Given this list of marker genes ZDHHC17, CDON (NCBI Gene Id 50937), GOLGA8J, ANO1, LIMCH1, RAB8B, FAM3C, GSE1, GOLGA6L4, SLC7A11, PITPNB, CCL8, PPIP5K2 (diphosphoinositol pentakisphosphate kinase 2), GTSE1, CNOT2, CHMP2B, TNS1, HAO1, PRKCD, KIF3B, PTPN22, TOM1L1, LIG4, SEC24C, GPD1L, ZNF586, MBOAT2, PAWR, EPC2, DEPTOR, PLAG1, SLC25A36, NCOA2, TAB3, IRS2, ZNF189, CHIC1, TBCEL (tubulin folding cofactor E like), CPOX, PAX5, NSUN7, ONECUT2, RIOX2, OXGR1, ZNF584, PALS1, PDE5A, GPBP1, ADRA1A, ETFBKMT, CALM1, GIGYF1, PCDHA6 (NCBI Gene Id 56142), KLHL42, TBC1D14, EPHA4, GCC2, LIN28A, LPCAT2, ZFP1, TTC39B (NCBI Gene Id 158219), ZNF544, ZFAND4, NLK, MAP2K1, RNF169, BIRC6, WDR82, TMEM64, DMXL2, MAMDC2, ACSL4, PHF3, MAPK1IP1L, TCF7L2, QKI, GHITM, ESR1, HECA, HRH1 (NCBI Gene Id 3269), TMLHE, KANK1, GOLGA8R, FIGN (fidgetin, microtubule severing factor), ZNF559, NOTCH2, OOSP2, LAMA1, ASTN1, GOLGA1, UBP1, SLC35F3, ZNF426, TAFA2, NAA50, NPEPPS, JARID2, FSBP, MSANTD3-TMEFF1, ATP8B2, SPRY4, TRIM2, IQCJ-SCHIP1, KDM5A, RLIM, RASSF8, POLQ, ACER3, C2orf69, PNRC2, ZEB2, RFC1, ADGRB3, ANKRD13C (NCBI Gene Id 81573), ARF6, PCDHAC2, GRB10, ATP2B2, PPP2R3A, TNF, SYNPR, KCNJ10, BOLL, DERL1, HIPK3, SCHIP1 (schwannomin interacting protein 1), ATMIN, ADAM11, IGF2BP2, CBLB, KLF15, ASPH, GPD2, HMBS (NCBI Gene Id 5448), ETNK1, PLCL2, PRDM4, ZNF844, RAD54B, MYO1E, GRM5, LOX, KLF6, BRWD1, PPP3R1, SOWAHA, SS18L1, BAG4, KPNA1, PLEKHJ1, RAB3IP, KLHL2, ATXN3, NOVA1, KATNBL1, ADCY1, ZIC2, ZNF121, ZNF527, MTPN, PTBP3, EYA3, GABRA1, TBC1D1, MIDEAS, TNRC6B (trinucleotide repeat containing adaptor 6B), MGAT2, S1PR1, CPNE2, NR6A1, KCNQ5, SYT16, GPR137C, DNAJC3, SLC2A3, NEXMIF, PCDHA11, KCNA1, ZNF37A, SLC38A11, YTHDC2, MFSD6, FAM135A, CPD, CREB1, ARHGEF3, TMEM94, UBE2B, REPS2, CCP110, RASSF1, NOTCH4, MB21D2, CXCL9, FNIP2, LIN28B, CEP97, GATA6, TMEM144, ATP2B3, HEY2, CHMP1B, LYRM1, HOXC8, PDE3A, N4BP2, GOLGA8M, PCDHA1, GOLGA8Q, ZBTB4, CREBRF, ADAMTS5, E2F7, WNK1, ZNF594, SIPA1L2, TNFSF4, PHF20L1, MED26, TREML4, CA8, NAP1L1, AHCTF1, CRIM1, ETV6, TGFBR1, ZNF700, FNDC3B, LRBA, NAB1, AGO4, CCNK, TPRX1 (tetrapeptide repeat homeobox 1), HOXD1, RAD21, BHLHE40, TRDN, ZNF597, MBTPS2, ABTB2, LCTL, ZFP90, FOXP1, HIC2, SLC5A9, APOO, STARD4, ATXN7, SIX4, YLPM1, CHD1, ZNF800, CARM1, PCDHA13, GOLGA8H, GOLGA8T, ITGA3, FSD1L, SSB, RAI1, PCDHAC1, DNAJA4, ZNF268, TRAK1, STXBP5, JADE2, ZFP36L2, CD69 (CD69 molecule), ZNF780B (NCBI Gene Id 163131), MARK1, NAALADL2, TCFL5, RBBP7, CNKSR2, ZNF439, PRTG, KMT2C, PAX9, ZFP36L1, NUS1, SMAP1, RPS6KA3, ABHD18, AFG3L2, DYNC2H1, ZNF124, ATP1B1, TXNDC12, DNAJC13, TMF1, AP1AR, CDKN3, UBE2D1, AKAP6, MORC3, LCLAT1, UNC5D, ANKRD44, RNF34, PCDHA2, FKBP1A, TBPL1, MYBL1, TBC1D4, RORA, MTX3, HCN2, FHIP1A, TAOK1, AK9, ZNRF2, FBXO34, PNMA2, BTBD3, SERTAD2, ENAH, GOLGA8N, PAPOLG, ASAH2B, THRB, BRD1, ZNF704, OSBPL8, RYR3, ADO, E2F5, RPS6KB1, TNFAIP1, TRIM71, ZNF781 (NCBI Gene Id 163115), CDK17, NIPBL, MAN2A1, YTHDF3, KIF1B, GPRIN3, PI4K2B, KMT2A, SEC24A, PLAU, ARL5A, LMO1, PKNOX2, SESN3, AKIRIN2, PCDHA9, BMP2K, SLAIN2, BAZ2B, CALCR, AP1S3, NIPAL4, SLC12A5, NR2C2, MTURN, SEMA4G, IPO7, MTF2, HEATR3, C14orf28, TRDMT1, PNISR, CFAP161, RIMKLB, ZNF440, CNTN4, ZFAND6, LEMD3, ACAP2, DCLK1, AIRIM, UBE2D3, FNDC3A, IL1A, ZFP62, SLITRK1, BLOC1S6, DEK, TAB2, CDC5L, LNPK, ACVR2A, DISC1, PRR27, CTTNBP2NL, ZFP14, GLS, TENT4B, PBX3, SH2B3, SIK3, KCNH1, TESMIN (testis expressed metallothionein like protein), SRGAP2, SCD, DCN, EN1, PROX1, INO80D, TMEM131, SPECC1L, LRRC8D, MEGF9, SSX2IP, CDH8, ADAMTS18, IPO8, PCDHA4, MIER3, PARM1, SPP1, ZNF780A, PDAP1, ZIC3, TMEM87B, KRBOX4, PSPC1 (paraspeckle component 1), ZNF773, LATS1, LPCAT1, AKT3, SLC10A7, KIF3A, COX15, CNKSR3, PAK5, ZNF563, ATP2A2, MYCBP2, CECR2, RNF217, HOXA1, ZNF479, DCBLD2, SLC4A8, NUCKS1, UBE3C, USP42, DOCK4, ETS1, CPEB4, ESM1, APBA1, ZNF140, SALL4, HYCC2, CBX7, KAT2B, TMED4, MBNL2, TMEM165, ATP2B1, ATXN1, B4GALT1, SIN3B, CDYL, FGD4, FBXO33, CBFA2T3, AMER2, KLHL29, NRXN1, RAB30 (RAB30, member RAS oncogene family), CCNJ, BRAP, DDX3X, PER3, WSB1, RALGAPB, GRIK2, ST8SIA4, ZDHHC7, ADARB1, SLC25A37, ADAMTS6, PDGFRA, MAP3K3, MICU3, AKIRIN1, ZDHHC3, ZNF823, KLHL5, TOGARAM1, AP1G1, RASSF2, ZNF266, PHLDA1, PCDHA10, CLIP1, BEND3, TGFBRAP1, SPIRE1, TNFRSF11B, IL2, ATM, OTOGL, C2CD5, RAB3C, POU2F1 (POU class 2 homeobox 1), MUC7, CDC73 (NCBI Gene Id 79577), LGALSL (NCBI Gene Id 29094), SELENOT, IKZF5, ZBTB2, PCDHA5, PABIR2, RNF182, BCLAF1, TM9SF4, PHIP, EYS, PRRC2C, OGFRL1, NKAIN2 (NCBI Gene Id 154215), ZNF468, KPNB1 (NCBI Gene Id 3837), EXOC5, NMBR, QSER1, ARMH4, XPO7 (exportin 7), PARP11, PTPN4, LARP4, ARMC8, NEK7, UBL3, NLN, TNPO1, G3BP2, SLC35E1, FUT9, PAM, KIAA1549L, IGDCC3, DUSP6, NR4A3, ST6GALNAC5, ZNF302, PSG11, NR1D2, PCDHA12, HOXA11, LRRN1, DLG2, RLF, VPS41, MUC22, OSBPL3, SACM1L (SAC1 like phosphatidylinositide phosphatase), IPMK, PIAS1, PCSK1, ZBTB43, PTPDC1, DARS1, OSBPL2, CTDSPL (NCBI Gene Id 10217), ENTPD6, PPFIA1, RECK, TMEFF1, CDC40, MS4A1, GSKIP, TCERG1, ADCY9, PCDHA7, PEAK1, CCNDBP1, ARSJ, NWD2 (NACHT and WD repeat domain containing 2), USP33, CLVS1, OTUD4, SRSF7, SAMHD1, SLC4A10, PCDHA3, AASDHPPT, CLASP1, MCC, RAB3GAP1, PCDHA8, PHTF2 (NCBI Gene Id 57832, putative homeodomain transcription factor 2), UNC80, GOT2, PAFAH1B2, HSP90B1, NCALD, BCL2L11, ACVR2B, AGFG1, MLXIP, TADA2B, BCL2, CPSF6, NELFA, PRLR, here is a description of the gene set: Genes predicted to be targets of miRBase v22 microRNA hsa-miR-181d-5p in miRDB v6.0 with MirTarget v4 prediction scores > 80 (high confidence targets). species: Homo sapiens Human Gene Set: MIR181D_5P from publication Chen Y, Wang X (PMID 31504780)